Given this list of marker genes TGFB1, NR4A1, PDGFB, TIMM17A, KRT18, VEGFA, PFKFB4, PPARA, PKM, LOX, AK2, EIF4A3, TPD52, IGFBP1, BATF3, ARHGAP5, STC2, PGAM1, PTGS1, PGK1, NOS1, FLT1, MT-CO1, HSP90B1 (NCBI Gene Id 7184), RRP9, RNASEL, ADORA2B, TEK, VEGFC, SIAH2, ODC1, GBE1, F3, ACAT1, NR3C1, IFI27, CNOT7, IL6, RPL36A, COL5A1, VEGFB, EDN1, IGFBP2, SLC2A1, P4HA1, HBP1, PROK1, MUC1, PFKFB1 (6-phosphofructo-2-kinase/fructose-2,6-biphosphatase 1), LDHB, SGSM2, HGF, TFF3, PNP, CXCR4, ABCB1, TF, PSMA3, SLC6A16, FKBP4, HAP1, PTGS2, DDIT3, TGFBI, HLA-DQB1, MT1L, ALDOC, PLAU, NFIL3, ALDH1A1, NOS2, LEP, CCT6A, SLC6A8, FGF3, XRCC6, TGFB3, TFRC (NCBI Gene Id 7037), QSOX1, EPO, HSPA5, ELL2, EFNA1, MMP2, BCL2L2, NT5E, HERC3 (NCBI Gene Id 9838), P4HA2, THBS1 (thrombospondin 1), SORL1, ENO1, LONP1, ERRFI1, BNIP3, CDK1, MXI1, DELEC1, NOS3, SERPINE1, IRF6, ANXA2, SLC16A1, VPS51, TNFAIP3, LDHA, CXCL8, ARSL, ADM, DKC1, SLC3A2, PNN, SLC20A1, CA12, MAP4, ENO3, ALDH1A3, VPS11 (NCBI Gene Id 55976), SIN3A, HMOX1, MIF (macrophage migration inhibitory factor), SAT1, SLC16A2, CA9, IGF2, HSPD1, PFKFB3, GPI, HK2, PLOD2, PAICS, CTSD, PPAT, AK3, PFKL, BPI, NDRG1, IGFBP5, BNIP3L, ANXA1, PLIN2, TXN, CITED2, TGM2, TXNIP (thioredoxin interacting protein), FOS, ITGA5, NFKB2, SLC2A3, SERPINB2, EGF, CLK1, LRP1, PLAUR, ZNRD2, KRT19, ICAM1, TBPL1 (NCBI Gene Id 9519), CDKN1B, CCNG2, PIM1, MMP7, DDIT4, HDAC1, HK1, BHLHE41, HMOX2, UMPS, ALDOA, RELA, BTG1, CALD1, JUN (NCBI Gene Id 3725), FN1, HIF1A, KDR, PGK2, EGR1, ETS1, BIK, EDN2, TP53, FABP5, CD99, ENPEP, MPI, PIM2, DR1, THBS2, PSMD9, PGF, ANGPT2, NFKB1, HERPUD1, GLRX, TPI1, ANGPTL4, PDK3, COL4A5, HDAC9, ID2, COL5A2, SIRPA, BIRC2, TH, COL5A3, FTL, CDKN1A, IGFBP3, RIOK3, INSIG1, TCEAL1, TPBG, SYT7, MT-CO2, CP, NOS2P2, SLC6A10P, SPP1, KRT14, HILPDA, TGFA, SLC6A6, HYOU1, VIM, ENG, SRSF6, ELF3, HSPH1, ART1, PGM1, BACE2, POLM, MMP13, BHLHE40, LGALS1, GAPDH, MTL3P, ANXA5, NSG1, NOS2P1, RBPJ, MET, BCL2L1, here is a description of the gene set: from publication Winter SC, Buffa FM, Silva P, Miller C, Valentine HR, Turley H, Shah KA, Cox GJ, Corbridge RJ, Homer JJ, Musgrove B, Slevin N, Sloan P, Price P, West CM, Harris AL (PMID 17409455) Human Gene Set: WINTER_HYPOXIA_METAGENE Genes regulated by hypoxia, based on literature searches. Affymetrix U133plus2 GeneChips were used to profile 59 head and neck squamous cell cancers. A hypoxia metagene was obtained by analysis of genes whose in vivo expression clustered with the expression of 10 well-known hypoxia-regulated genes (e.g., CA9, GLUT1, and VEGF). To minimize random aggregation, strongly correlated up-regulated genes appearing in >50% of clusters defined a signature comprising genes, of which 27% were previously known to be hypoxia associated. The median RNA expression of the genes in the signature was an independent prognostic factor for recurrence-free survival in a publicly available head and neck cancer data set, outdoing the original intrinsic classifier. In a published breast cancer series, the hypoxia signature was a significant prognostic factor for overall survival independent of clinicopathologic risk factors and a trained profile. The work highlights the validity and potential of using data from analysis of in vitro stress pathways for deriving a biological metagene/gene signature in vivo. species: Homo sapiens